The following is a description of a gene set: Abnormal CD4+ T cell subset proportion Abnormal increase or decrease of helper CD3+CD4+ T cells, measured as percentage of total CD3+ T cells in the blood, compared to a reference range for a given sex and age-group. These are usually measured within the TCR alpha/beta positive population. Human Gene Set: HP_ABNORMAL_CD4_T_CELL_SUBSET_PROPORTION species: Homo sapiens, and this is the list of marker genes: CARD11, UNC119, RFXAP, RFXANK, PSMB10 (NCBI Gene Id 8138), TOM1, RASGRP1, CTNNBL1, ITK (IL2 inducible T cell kinase), DOCK8, KDM6A, OTULIN, CASP10, IVNS1ABP, PIK3CG, KMT2D, IL7R, HLA-DPB1, CIITA, LEP, CD4, FOXN1, LCP2, POLD1, SMARCAL1, KNSTRN, IKBKB, MYC, BLM, ATM, WAS, MAGT1, ATP6AP2, LAT, SASH3, CARD9, CD3E, DEF6, IL2RA, RFX5 (NCBI Gene Id 5993), IL2RG, FAS, LEPR, PIK3CD, POLD3, SEC61A1, BCL11B (BCL11 transcription factor B), FASLG, BCL10, EPG5, EXTL3, LCK, PIK3R1, PGM3, DIAPH1, NSMCE3